Given this list of marker genes NFKBIL1, TRIM40, SETD6, PRMT2, ERBIN, PYCARD, TMIGD3, NFKBIA, PYDC2, MTURN, LRRC14, TRIM21, PYDC1, TRAF3, ARRB1, CHUK, OTULIN (OTU deubiquitinase with linear linkage specificity), NLRC3, NWD1, ADORA3, UFL1, COMMD6, PKHD1, BRMS1, TCEAL7, TRIM37, BCL3, CHP1, CYLD, CACTIN, COMMD1, COMMD7, PARP10, RWDD3, NLRC5, RBCK1, GFI1, CMKLR1, USP7, FOXP3, HAVCR2, CDK5RAP3, ACOD1, CYP1B1, NLRP2B, SIRT1, AIM2, PSMD10, ARRB2, here is a description of the gene set: Any process that stops, prevents, or reduces the frequency, rate or extent of the activity of the transcription factor NF-kappaB. species: Homo sapiens Human Gene Set: GOBP_NEGATIVE_REGULATION_OF_NF_KAPPAB_TRANSCRIPTION_FACTOR_ACTIVITY